Given this list of marker genes NMNAT3, NADSYN1, PARP9, PARP16, NMNAT2, NAXD, NAMPT, NNMT, BST1, NAXE (NCBI Gene Id 128240), PARP8 (poly(ADP-ribose) polymerase family member 8), SLC22A13, PARP14, RNLS, NADK2, QPRT, PARP10, NMRK1, NMNAT1, PARP4 (NCBI Gene Id 221181), NMRK2, PARP6, NT5E, CD38, NAPRT, SLC5A8, NADK, NUDT12, SLC25A51, here is a description of the gene set: part of: Metabolism of water-soluble vitamins and cofactors species: Homo sapiens Reactome Pathway: Nicotinate metabolism Nicotinate (niacin) and nicotinamide are precursors of the coenzymes nicotinamide-adenine dinucleotide (NAD+) and nicotinamide-adenine dinucleotide phosphate (NADP+), essential cofactors in many redox reactions. The cytosolic reactions that generate NAD+ can be classified into three groups (Cambronne & Krause 2020; Covarrubias et al. 2021; Magni et al. 2004). First, in the de novo or kynurenine pathway, ACS derived from tryptophan catabolism is spontaneously converted to QUIN, which in turn is converted successively to NAMN, NAAD, and NAD+ in reactions catalyzed by QPRT, NMNAT2, and NADSYN1. These are the first four reactions listed here. Second, in the Preiss–Handler pathway, the next three reactions listed here, extracellular nicotinate (NCA), transported into the cytosol by SLC22A13 or SLC5A3, is converted to nicotinate D-ribonucleotide (NAMN), which can enter the de novo pathway to be converted to NAD+.<p>The remaining large group of reactions enables the modulation of nicotinamide (NAM) levels and the regeneration of NAD+ from diverse metabolic intermediates. Enzymes that play central roles in these processes include nicotinamide phosphoribosyltransferase (NAMPT), and nicotinate phosphoribosyltransferase (NAPRT1). These enzymes are poorly characterized in humans, despite their importance in NAM utilization. NAM levels are also regulated by nicotinamide N-methyltransferase (NNMT), a potential regulator of diet-induced obesity.<p>Reactions mediating parts of these processes but localized to the nucleus, mitochondria, and peroxisomes are also included in this pathway.